The following is a description of a gene set: Mouse Gene Set: GOBP_OSSIFICATION The formation of bone or of a bony substance, or the conversion of fibrous tissue or of cartilage into bone or a bony substance. species: Mus musculus, and this is the list of marker genes: Col11a2 (collagen, type XI, alpha 2), Nab1 (NCBI Gene Id 17936), Ano6, Alox5, Mir342, Tmem38b, Hdac8, Il6st, Setd2, Suv39h1, Mir23b, Sp3, Bcor, Rbpj (recombination signal binding protein for immunoglobulin kappa J region), Mir193b, Fgfr1, Tent5a, Traf6, Ebp, Runx1, Bmpr1a, Ptger4, Calca, Osr1, Jund, Nell1, Myoc, Phospho1, Ptk2, Ifitm5, Smad5, Prkd1, Mir290a, Acvr2b, Acvr1b, Smpd3, Mir125a, Mir483, Gpc3, Cebpd (CCAAT/enhancer binding protein delta), Clic1, Ranbp3l, Mir125b-1, Apc, Tob1, Ptpn11, Mir671, Ddr2, Adgrv1, Cnmd, Txlng, Hoxa3, Asxl2, Six2, Fgfr3, Bmp7, Mapk3, Clec5a (C-type lectin domain family 5, member a), Scx, Ucma, Mir15a, Zfp932, Osr2, Tgfbr3, Sirt7, P2rx7, Limd1, Mir130a, H3f3b, Pth, Atp6v0a4, Clec3a, Hif1a, Wnt11, Grem1, Csf1r, Mir204, Mir16-1, Akt1, Nfix, Erfe, Ptch1, P2ry2, Scube2, Yap1, Alpl, Ccl3, Glis1, Myog, Kl, Mir15b, Col1a2, Aspn, Mir133a-1, Twist1, Id4, Runx3, Igsf10, Col1a1, Gnas, Vegfc, Fzd9, Mmp16, Col5a2, Klf10, Cyp27b1, Alox15 (arachidonate 15-lipoxygenase), Col6a1, Gli3, Snai2, Hspg2, Gpnmb, Smoc1, Thrb, Sfrp1, Vegfa, Gdpd2, Mir217 (NCBI Gene Id 387213, microRNA 217), Mir378d, Mir211, Slc24a3, Ercc2, Hdac4, Prickle1, Axin2, Zbtb16, Mir34b, Ctnnb1, Tcirg1, Hemgn, Mir16-2, Mesd, Fstl3, Dmp1, Riox1, Lncpint (NCBI Gene Id 232685), Mir19b-2 (microRNA 19b-2), Sgms2, Mir296, Sp7, Enpp1, Sox8, Chrdl1, Pex7, Gm15222, Calcr, Mir125b-2, Runx2, Rsad2, Sik3 (NCBI Gene Id 77161), Ostn, Fat4, Id1, Prkaca, Galnt3, Mir31, Foxc2, Ext1, Myf5, Notum, Mir128-2, Zhx3, Rpl38, Pparg, Adrb2, Tnfaip6, Bmpr1b, Atraid, Bglap (bone gamma carboxyglutamate protein), Creb3l1, Fam20c, Map3k7, Mtss1, H3f3a, Gpld1, Fhl2, Satb2, Mir3065, Gabbr1, Mir199a-1, A430033K04Rik, Thra, Cer1, Wwtr1 (NCBI Gene Id 97064), Pam16l, Ski, Rflnb, Bmncr, Hoxa2, Tmt1a2, Atf4, Ptgs2, Fermt2, Mir134, Rogdi, Fgf2, Fgf23, Sfrp2, Ibsp, Grp, Col2a1, Mir214 (microRNA 214), Tmem64, Comp, Prl, Gdf5, Smad2 (SMAD family member 2), Igfbp5, Epha2, Casr, Ipo7, Cebpa, Mir30c-1, Smurf1, Clec11a, Smad4, Hira, Bmp8a (NCBI Gene Id 12163), Ppp3ca, Chsy1, Gas5 (NCBI Gene Id 14455), Dlk1, Mir183, Penk, Bmpr2, Ltf, Dhh, Mmp2, Fbn2, Sbno2, Map2k6, Adcy10, Cbfb, Nipbl, Tmco1, Pdlim7, Tapt1, Adamts7, Igf1, Men1, Lep, Bcl2, Ccn3, Mir2861, Cited1, Mir23a, Shox2, Nfe2, Ank, Smo, Gdf10 (growth differentiation factor 10), Minpp1, Dhx36, Mgp, Icmt, Bpnt2, Mir5100, Mirlet7b, Mepe, Mapk11, Fignl1, Mir210, Atp2b1, Isg15, Tfap2a, Mir25, Slc26a2, Scube3, Mir378b, Mia3, Tnf, Kazald1, Ache, Wwox, Mir199a-2, Ahr, Lrp3, Bmp8b, Gfra4, Mapk1, Igfbp3, Hdac5, Nr1i3, Nppc, Trp63, Csgalnact1, Ccn4, Ifitm1, Cyp24a1, Chrdl2, Gpm6b, Mef2c (myocyte enhancer factor 2C), Mmp14, Col10a1, Tcf7l2, Id3, Asgr2, Sox2, Phex, Nog, Mir140, Panx3, Mir128-1, Rflna, Tmt1a3, Gli2, Sbds, Bglap3, Lrp6, Fgf18, Ihh, Fto, Esrra, Gsk3b, Git1, Inppl1, Ift80, Mir877, Kremen1, Rhoa, Dkk1, Gcm2, Erh, Stc1, Mirlet7i, Lrp4, Lef1, Mir30c-2, Mkx, Pam16, Tmt1a, Mir135a-1, Mdk, Mir27a, Ltbp3, Junb, Bmp1, Sh3pxd2b, Gata1 (GATA binding protein 1), Ffar4, Nf1, Rest, Sp1, Rspo2, Dnai3, Foxc1, Mir22 (microRNA 22), Dhrs3, Mir99a, Ecm1, Bmp6, Mapk8, Sost, Ccn1, Fgfr2, Lmna, Ccdc134, Ahsg, Mmp13, Fgr, Tnn, Cthrc1, Wnt3, Srgn, Gdf2, Ccdc154, Pkdcc, Egr2, Acvr2a, Ext2, Ctnnbip1, Sox9, Ccr1, Ptk2b, Mir24-2, S1pr1, Xylt1, Trpm4, Mir20a, Mir191, Ctsk, Jag1, Fzd1 (frizzled class receptor 1), Snai1, Nbr1, Acvr1, Oxt, Clec3b, Mir338, Notch1, Tacr1, Mir132, Ryr1 (ryanodine receptor 1, skeletal muscle), Adamts12, Mir34a, Cdk6, Gla, Igf2, Ripply2, Tph1, Col11a1, Smad3, Sort1, Tnfrsf11a, Bmp3, Actn3, Npr2, Sun1, Hey1, Cst5 (NCBI Gene Id 58214), Lox, Mn1, Spp1, Fbxl15 (NCBI Gene Id 68431), Ilk, Prmt3, Wnt7b, Lrrc17, Hand2, Adar, Fgf9, Mir24-1, Mir133a-2, Bmp4, Bmp5, Rassf2, Ppargc1b, Pbx1, Dchs1, Tob2, Mir1897, Trp53inp2, Dlx5, Sox11, Gja1, Mir19b-1, Matn1, Wnt3a, Eif2ak3, Noct, Nfatc1, Mir137 (microRNA 137), Chrd, Bmp2, Smad7, Twist2 (twist basic helix-loop-helix transcription factor 2), Rxrb (NCBI Gene Id 20182), Mir30a, Suco, Mapk14, Bmp2k, Ifi204, Wnt10b, Wnt5a, Asf1a, Atp6v1b1 (ATPase, H+ transporting, lysosomal V1 subunit B1), Csf1, Bglap2, Ccn2, Areg, Shh, Col13a1, Tnfsf11, Crim1, Fbxo5, Hdac7, Slc20a2, Kremen2, Smad1, Cebpb, Intu, Lrp5, Mir34c, Tgfb1, Ptn, Mef2d, Sema4d, Ddx5, Dnm3os, Ccr1l1, Gli1, Lgr4, Msx2, Snx10, Twsg1, Mir378a, Zmpste24, Igfbp2, Duox2, Mir3960, Thbs3, Nab2, Mir205, Bambi, Fosl2, Smad6, Npnt, Slc8a1, Mir188, Pth1r, Tmem119, Fkrp, Fndc3b, Pthlh, Rxra, Tac1, P3h1, Vdr, Mir370, Id2, Tmem53, Cd276, Plxnb1, Wnt4, Herc1, Cbs, Ankrd11, Il6, Rorb